Given this list of marker genes Cd9, Gstm1, Lgals4, Lap3, Msln, Cdh1, Cd81, Eno3, Ctsz, Hgfac, Pgk1, Cant1, Psmb1, Npc2, Agrn, Me1, Glod4, Gm4802, Lgals3bp, Vcp, Psma3, Got1, Set, Cdh17, Wdr1, Acta2, Ywhaq, Hmgb1, Prss1, Msn, Prdx1, Capg, Rack1, Actn1, Ywhab, Sparc, Atp6ap2, Cfb, Col18a1, Cx3cl1, Vcam1, Col1a1, Actn4, Psma1, Actb, Psmb6, Impa1, Tinagl1, Eef2, Fam3c, P4hb, Kxd1, Cst3, Ctsd, Timp2, Arhgdia (NCBI Gene Id 77176), Gsto1, Psmb5, Chaf1a, Pkm, Psmb4, Cp, Gpi1, Glo1, Anxa4 (NCBI Gene Id 269772), Serpinb6a, Rpl10a, Pgam2, Lmna, Vcl, Tnxb, Calr, Sdc4, Fuca1, C2, Uba52, Psma5, Npm1, Gsr, Rhoa, Ppic, Enpp2 (ectonucleotide pyrophosphatase/phosphodiesterase 2), Fn1, Akr1b1, Kctd7 (NCBI Gene Id 212919), Gstp1, Eno1, Trf, Krt73, Pnp, Ywhah, Bgn, Dnpep, Ecm1, Lxn, Spp1, Ldha, Tpi1, Nucb1, Ahsg, Itih2, Prl2c2 (prolactin family 2, subfamily c, member 2), Mtap, Pebp1, Clu, App, Hsp90b1, Ywhaz, Mdh2, Tpt1, Ctsb, Slk, Park7, Apoh, Ywhae, Hsp90ab1, Eef1a2, Psmb3, Ctrb1, Phactr4, Psma7, Ran, Cytip (NCBI Gene Id 98984), Psmb2, Hprt1, Prdx6, Serpinc1, Rpl18a, Psma4, Qsox1, Gsta4, Sema3c, Clstn1, Aldoa, here is a description of the gene set: studied in species Mus musculus Mouse Gene Set: ZHONG_SECRETOME_OF_LUNG_CANCER_AND_FIBROBLAST Proteins secreted in co-culture of LKR-13 tumor cells (non-small cell lung cancer, NSCLC) and MLg stroma cells (fibroblasts). from publication Zhong L, Roybal J, Chaerkady R, Zhang W, Choi K, Alvarez CA, Tran H, Creighton CJ, Yan S, Strieter RM, Pandey A, Kurie JM (PMID 18757440) Non-small cell lung cancer (NSCLC) cells with somatic mutations in K-ras recruit to the tumor a variety of cell types (hereafter collectively termed stromal cells) that can promote or inhibit tumorigenesis by mechanisms that have not been fully elucidated. Here, we postulated that stromal cells in the tumor microenvironment alter the tumor cell secretome, including those proteins required for tumor growth and dissemination, and we developed an in vitro model to test this hypothesis. Coculturing a murine K-ras mutant lung adenocarcinoma cell line (LKR-13) with a murine lung stromal cell (macrophage, endothelial cell, or fibroblast) enhanced stromal cell migration, induced endothelial tube formation, increased LKR-13 cell proliferation, and regulated the secretion of proteins involved in angiogenesis, inflammation, cell proliferation, and epithelial-to-mesenchymal transition. Among these proteins, CXCL1 has been reported to promote NSCLC development, whereas interleukin-18 (IL-18) has an undefined role. Genetic and pharmacologic strategies to inhibit CXCL1 and IL-18 revealed that stromal cell migration, LKR-13 cell proliferation, and LKR-13 cell tumorigenicity required one or both of these proteins. We conclude that stromal cells enhanced LKR-13 cell tumorigenicity partly through their effects on the secretome of LKR-13 cells. Strategies to inhibit tumor/stromal cell interactions may be useful as therapeutic approaches in NSCLC patients.